The following is a description of a gene set: studied in species Mus musculus Mouse Gene Set: GOBP_GLYCINE_TRANSPORT The directed movement of glycine, aminoethanoic acid, into, out of or within a cell, or between cells, by means of some agent such as a transporter or pore., and this is the list of marker genes: Slc6a9, Slc6a14, Slc25a38, Slc36a3, Slc36a2, Slc6a20b, Slc7a8, Slc32a1, Slc38a5, Slc38a1, Slc36a1, Slc6a17, Slc6a5, Rgs4, Rgs2, Slc6a7, Slc6a20a, Slc7a10 (solute carrier family 7 (cationic amino acid transporter, y+ system), member 10)